Given this list of marker genes APOBEC3C, ARPC3, PRF1, PIM3 (Pim-3 proto-oncogene, serine/threonine kinase), ENSA, PSMB1, LAP3, UBE2B, LMNB1, RHOA, NR3C1, RBM3, PAM, PPP4R2, CD3D, NDUFS6, HNRNPLL, SF3B5, RBM8A, PMAIP1, CBX3, PLP2, SMC4, ELOB, DNAJB14 (DnaJ heat shock protein family (Hsp40) member B14), IQGAP1, RAB11A, HAVCR2, POLR2G, SNRPD3 (small nuclear ribonucleoprotein D3 polypeptide), CXCR6, SLC25A5, TGIF1, HERPUD1, TNFRSF9, PHTF2, IL2RG, GEM, BIRC3, HNRNPA3, TRAPPC1, CXCL13, HNRNPA1, RANBP1 (NCBI Gene Id 5902), BTG3, PHLDA1, SPCS1, NDUFA12, MAD2L2, HIF1A, PSMA4, NDUFB11, EID1, GBP1, HSBP1, SLBP, PDIA6, MDH1 (NCBI Gene Id 4190), PAPOLA, NUCKS1, SH2D2A, ACTN4, NIBAN1, HLA-DPB1, MPG, VOPP1, CALM3, IGKV3-20, PTMS (parathymosin, NCBI Gene Id 5763), PFN1, HLA-DMA, ENO1, TRIM22, GZMH, PPIB, TXN, ACP5, SRSF3, SNRPG, RABAC1, IFI16, CDC123, RHBDD2, SMS, PSME1, HSPA5, MT2A, SP140, ATP2B1, TMPO, FKBP5, IGFLR1, CREM, LDHA, HLA-DPA1, RNF19A, RTRAF, EWSR1, SH3BGRL, IGKV1-5, LCP1, BANF1, FABP5, RNF181, NPM1 (nucleophosmin 1), CD99, NDUFB3, SNRPD1, CYB5R3, HLA-DRB5, IFI6, TXNDC17, PRDX6, DNPH1, NASP (nuclear autoantigenic sperm protein), UBE2L6, ROMO1, POMP, CAPZB, ANXA6, HNRNPR, SEC61G, ATP5F1B, SNAP47, PRDX5, IGKV4-1, YWHAB, IFITM2, SUMO2, PSMB6, ATP5MC3, CORO1A, GPI, FKBP1A, CYTOR, ISG15, TMSB10, PPP1CA, NUDT1, ID2, LGALS1, SUB1, HLA-DRA, NDUFB4, PTMA, CDKN2A, AIP, ATP5MC2, UBB, TALDO1, PGAM1 (phosphoglycerate mutase 1), B2M, SFXN1, PPM1G, HLA-DQB1, CARHSP1, VIM, HLA-B, VDAC1, CD7, UBE2L3, NKG7, XRCC5, GBP5 (NCBI Gene Id 115362), SEC61B, BLOC1S1, NUDT21, TIGIT, PSMD8, S100A4, CHCHD2, SEM1, LAPTM5, XCL1, GNG5, RPS27L, DCTN3, RGS1, IFITM1, GMFG, DEK, ARF1, NDUFS5, OASL, ARPC5, BSG, HLA-A, RILPL2, UBE2A, MT1E, BST2, PRDM1 (NCBI Gene Id 639), IDH2, PSMC3 (proteasome 26S subunit, ATPase 3), COX5A, TOX, MCM5 (NCBI Gene Id 4174), PSMB8, HNRNPA2B1, TUBA1B, YWHAQ, TUBB, HLA-DRB1, CALM2, ANAPC11, MIR4435-2HG, COX7A2, CLTA, RAB27A, ADGRG1 (adhesion G protein-coupled receptor G1, NCBI Gene Id 9624), DYNLL1, NAP1L1, ATP5F1D, PELI1, IGKC, SIRPG, MDH2, SLA, LMNA, PPIA, SRI, SAP18, ALDOA, CHMP2A, GALM, SNX9, ITGAE, RALY, TMEM14C, JAML, TNFRSF1B, ATP5IF1, COX6A1, PSMA7, H2AZ1, CTSW, GBP2, CCND2, RALA, PTPN7, ANP32E, PSMC5, DUSP4, CD8A, COTL1, NONO, MACROH2A1 (NCBI Gene Id 9555), ARPC2, GRB2, PSMB2, VAMP5, IFT25, ILF2 (NCBI Gene Id 3608), PSMB3, LSP1, CDK2AP2, GET3 (NCBI Gene Id 95857), MAP2K3, MRPL52, SNRPC, TNFRSF18, TSPO, STAT1, COX17, PPP1CC, APOBEC3G, CTSB, PDAP1, ERH, ZFP36L1, IFITM3 (NCBI Gene Id 10410), TAX1BP1, PSMB9, BZW1, WNK1, RAC1, RPA3, SOD1 (NCBI Gene Id 6647), LAG3, TPM4, RBPJ, STMN1, ZNF331, SEC11C, COX5B, COX6B1, CD2BP2 (NCBI Gene Id 10421), PCED1B, CAP1, COX8A, LSM2, LY6E, EPSTI1, ATP5PB, CKS2, S100A11, ARPC5L, HPRT1, MX1, TMSB4X, CD82, SNRPF, PTTG1, GZMB, MYL12B, ISG20, ATP5PF, SNRPB, MIR155HG, SMC1A, FAS, IGLV3-21, NDUFV2, CARD16, PSMD4, TPM3 (tropomyosin 3), NAMPT, NHP2, ANP32B, OAZ1, UBL5, HMGB2, TSHZ2, LGALS3, MTHFD2, HNRNPC, HMGN2, AREG, IL2RB, IGKV3-11, RGCC, RPS26, CD27, CD2, CLEC2B, GAPDH, IGHG1, ATP5MF, PPDPF, SRGN (serglycin), CALR, CCDC167, ZYX, COX7B, PHPT1, COPE, RBX1, IGKV3-15, PDIA3, BBLN, RAD21 (RAD21 cohesin complex component), ACTB, BATF, LIMS1, DBI, SEC11A, CTSD, SH3BGRL3, ICOS, ARF5, PKM, ANXA5, CBLB, KPNA2, AKIRIN2 (NCBI Gene Id 55122), SRP14, HMGB1, UBC (NCBI Gene Id 7316), PDCD1, FIBP, ITM2A, TPI1 (NCBI Gene Id 7167), MYL6, COX6C, TMEM258, BHLHE40, IFI27L2, PSME2, ENTPD1, PTPN22, CD226, PARK7, SLC25A3, EIF6, CTLA4, CD63, HLA-DQA1, ALOX5AP, ATP5MG, HSD17B10, H2AZ2, TYMP, CCL3, AHI1, CTSC (cathepsin C), NDUFA6, CFL1 (cofilin 1), SP100, TBC1D4, XRCC6, CD74, PGK1, ARID5B, NDUFA4, GSTO1, TAP1, SAMSN1, TANK, LINC00649 (NCBI Gene Id 400863), LYST, HLA-C, ACTG1, CLIC1, PRDX3, HMGN1, DRAP1, ATP5F1C, WDR83OS, DCTN2, HNRNPK, PRDX1, RAN, NDUFS3, RGS2, here is a description of the gene set: studied in species Homo sapiens Human Gene Set: JIANG_MELANOMA_TRM3_CD8 Tissue-resident memory T cells (TRM) are a specialized T cell population residing in peripheral tissues. The presence and potential impact of TRM in the tumor immune microenvironment (TIME) remain to be elucidated. Here, we systematically investigated the relationship between TRM and melanoma TIME based on multiple clinical single-cell RNA-seq datasets and developed signatures indicative of TRM infiltration. TRM infiltration is associated with longer overall survival and abundance of T cells, NK cells, M1 macrophages, and memory B cells in the TIME. A 22-gene TRM derived risk score was further developed to effectively classify patients into low- and high-risk categories, distinguishing overall survival and immune activation, particularly in T cell-mediated responses. Altogether, our analysis suggests that TRM abundance is associated with melanoma TIME activation and patient survival, and the TRM-based machine learning model can potentially predict prognosis in melanoma patients. from publication Jiang C, Chao CC, Li J, Ge X, Shen A, Jucaud V, Cheng C, Shen X (PMID 38455971)